Given this list of marker genes Coro1a, Pik3cb, Il18rap, Pvr, H2-T23, Arrb2, Cd96, Serpinb9 (serine (or cysteine) peptidase inhibitor, clade B, member 9), Stx11, Arl8b (NCBI Gene Id 69275), Havcr2, Fcgr4, Raet1e, Kctd9, Klre1, Serpinb9e, Slamf6, Rasgrp1, Klrc3, H60b, Il12b, Ulbp3, Rab27a, Igf2, H2-M3, Cd2, Cd160, Tgfb1, Rasgrp4, Serpinb9h, Inpp5d, Clec2d, Crk, Cadm1, Lamp1, Klri1, Ceacam1, Klrb1b, Rnf19b, Raet1d, Klrc2, Serpinb9b, Pik3r1, Lep, Cd226, Unc13d, Il18, Ulbp1, Nkg7, Sh2d1b2, Vav1, Gzmn, Dpp4, Kif5b, Gzmc, Gzmb, Gimap5, Serpinb9d, Klrb1 (NCBI Gene Id 67401), Prdx1, Pik3r6, Serpinb9f, Serpinb9g, Sh2d1b1, Serpinb9c, Hcst, Ap1g1, Mill1 (NCBI Gene Id 266815), Nectin2, Clnk, Nectin4, Ptpn6, Calhm6, Ncr3-ps, Klrb1f, Il21, Grb2, Lyst, Stat5b, Tap2, Klrk1, Crtam, Sh2d1a (NCBI Gene Id 279676), Klri2, Klrc1, Clec12b, Plekhm2, Gfer, Klrb1a, Klrd1, Lgals9, Lag3, Il12a (interleukin 12a), Stat5a, Klrb1c, Tap1, Cebpg, H60c, Gimap3, here is a description of the gene set: species: Mus musculus Mouse Gene Set: GOBP_NATURAL_KILLER_CELL_MEDIATED_IMMUNITY The promotion of an immune response by natural killer cells through direct recognition of target cells or through the release of cytokines.